Given this list of marker genes COPS5P1, MTND5P11, KAT8, FAM177A1P1, ANKDD1A, ACACA, MIR3162, SORBS2, WEE2-AS1, SPATS2L, VPS13B-DT, OR1X5P, ACER3, GBA1, EGFEM1P, LUZP1, CCT6B, VPS39, AP1S3, SNAI2, COQ10A, RNF220, MB, TTC1, ANGEL1, MX1, DACH1, CROCCP3, HMGA2, NPLOC4, STX4, COPS3, PIGL, RN7SL128P, MDM2, TULP2, NOL6, ELAC2, RNU6-916P, IGSF21, ZNF461, VTRNA1-3, HNRNPMP2, TPM4P1, CYP1B1-AS1 (CYP1B1 antisense RNA 1), MAP4K5, ZNF581, SLC22A11, UTP4, RNU6-847P, CLIP1, ZEB2P1, SKAP1, RN7SL93P (RNA, 7SL, cytoplasmic 93, pseudogene), UBXN7-AS1, SEC22B, SLC31A2, CFAP299, TNFRSF10B, PPP1R42 (NCBI Gene Id 286187), YEATS2, LARS1, SDAD1P3, GTF2I, FABP5P3, TRMT44, GDI2, GC, MTF2, INTS5, SH2B3, TNFRSF12A, FCHO2, JPX, PLA2G4C, ATP9B, GADD45B, BORCS6, NAPSA, CHEK2, IL16, HMGB1, ZNF609, HAPLN2, CARS1, COX16, RRN3P1, PPATP1 (NCBI Gene Id 5472), GIN1, GABARAPL3, LINC01235, LIM2-AS1, TOP3B, VPS13B, CLDN23, SSX7, PPIP5K2, RORA, MED21, SPMIP10, OR5AQ1P, MIX23, TM9SF4, ANGPTL6, RPL32P27, LPGAT1, CD2AP, GALNTL5, ENSG00000233242, ZNF557, CFAP298-TCP10L, SLC49A4, DHTKD1, SH3RF2, DAZAP2, DMAP1, SNRPB, TRAV15, MIR3611, ILDR1, C1orf87, ZNF580, RFC1, KRT18P45, YAP1P1, CNOT4, HSPBAP1, RPL39P18, MIR764, RNU1-141P, MCTS1, ENSG00000265246, PRAMEF29P, IFI6, VTRNA1-2, MIR4510, CTNNA2, KCTD5, LIPA, TGFB1, PTK2B, ADA (adenosine deaminase), PJA2, AGMAT, SETD5, VOPP1, RNU6-386P, CREB3L4, MRPS31P5, SMARCD2, CXXC1, FAM149B1, RFTN1, TMEM98, ZNF675, ENSG00000266088, RNU6-1039P, CCDC40, GAS8, E2F7, PTPN2 (protein tyrosine phosphatase non-receptor type 2), ASS1P5, LINC00929, ZNF566, MTCO3P12, SLC6A1, ABR, ENSG00000202059, MBTPS2, TLX1NB, ESPN, JAZF1-AS1, SMCR2, ITIH3, GDPD5, ENSG00000244137, SNAP25, FMN2, PMM1 (NCBI Gene Id 5372), TPRXL, ENSG00000200235 (NCBI Gene Id 124900208), RPS27P6, ZNF568, LINC02390, FOXP1-AS1, OR1X1P, SLEAR, LYN, TLX1, SNHG30, C7orf50, NCOR2, RNU6-1340P, TRPV1, DPP9, TLE3, CELF2-AS2, CCDC65, SLC25A16, THADA, CASD1, GTPBP3, BMS1, CWC25, GXYLT2, CMKLR2-AS, LYPLA2P1, NEUROD2, MLST8, H3P10, C2CD5-AS1, WDR11, LINC01641, SDC4, PFAS, NME1-NME2, CFAP298, LINC01897, IFT57P1, SYCE2 (synaptonemal complex central element protein 2), MORF4L1P5, TARS2, SRSF8CP, GPATCH8, HEBP2, ZNF391, EIF3F, DDX46, TMEM79, UMOD, MIR3529, TTLL13, ZNF863P, FKBP1A, NLE1, ANKRD54, WNT8A, KDSR, SLC9A1, DAGLB, CD160, MTFMT, PLA2G15 (NCBI Gene Id 23659), PVT1, FES, ANO8, RNA5SP474, LINC00581, MT-TP, NPAT, WDR11-DT, DNAI4, ITGAL-AS1, CEP170, RNU6-142P, EXOSC2, COL25A1, CDCA7P1, SHOC1, B3GALNT2, ZBTB45, RPL37, SMG5, GLG1, AKAP9, SAMD13, SSBP1, TNRC18, SMG8, SOX9-AS1, TMX1P2, ALG10B, ST7L, RND1, ECD, NME1, ENSG00000187951, DUS2, MTND1P14, SLFN12, AURKB, PAFAH2, RNU6-612P, ZNF829, ALDOA (NCBI Gene Id 226), RNU6ATAC36P, RPL27 (ribosomal protein L27), ENSG00000243004, SCN3B, TRPM6, CDC37, RB1CC1, SLC33A1, LTK, RPL36, TRIM15, MAPK6P4, MTO1, RPL36P2, BBLNP1, LINC01485, JHY, AURKAIP1, OR7A17, TRIM55, INTS12, RLIG1P2, USPL1, PTPRM, FRMD7, CBFA2T2, GLRX5P2, CENPV, RNU6-166P, NFYC, NUCB1-AS1, SNORD81, LRP1B, GIT2, USB1, RN7SKP270, GSTCD, H3P44, UTP3, TCEAL8P1, RNU4-62P, SPEG, C6orf141, ARPC1A, CCNB3, QSER1, MIR3908, CEACAM21, CDK4, ARMH3, DOCK8-AS2, RPL3P1, WDR62, TAMM41, LINC02576, MLEC, RNU6-1003P, ACKR2, here is a description of the gene set: Genes containing one or more binding sites for (ZNF34) in their promoter regions (TSS -1000,+100 bp) as identified by GTRD version 20.06 ChIP-seq harmonization. from publication Yevshin I, Sharipov R, Kolmykov S, Kondrakhin Y, Kolpakov F (PMID 30445619) studied in species Homo sapiens Human Gene Set: ZNF34_TARGET_GENES